Given this list of marker genes CYP4X1, FANCG, SNAI1, REV1, SIRT3, FZD7 (frizzled class receptor 7), TEX261, RBM4, EDIL3, SLC9A9, SSH3, CTSH, PAN3, ASAP1, TAOK1, APC, NAALADL1, VCF2, FMOD, LGALS1, G0S2 (G0/G1 switch 2), TMEM119, BTBD8, MANEA, ZC3H10, SUCLA2, FAM161A, SOX17 (SRY-box transcription factor 17), CP, SLC18A1, UCHL1, MS4A6A, CRH, BHLHE41, SGIP1, DLEU2, SUFU, ABL2, BMPR2, XAGE1A, SHCBP1, CRIM1-DT, IRF4, S100A12, PRKAA2, HEY1, LTBP1, C11orf96 (chromosome 11 open reading frame 96), WDR81, HMG20A, TNNI3K, ARHGAP36, SLC2A2, USP31, PSME4, SOAT1, MS4A4A, GABPA, PART1, CD86, MAP9, TTC38, PAX8, GPR108, ARID4A, RNF32-DT, NDUFA10, ACER3, EEF1AKMT2, CLDN12, ACVR2A, ALDH8A1, TCFL5, here is a description of the gene set: Genes up-regulated in normal keratinocytes immortalized by infection with the high risk HPV31 (human papilloma virus) strain. species: Homo sapiens Human Gene Set: CHANG_IMMORTALIZED_BY_HPV31_UP from publication Chang YE, Laimins LA (PMID 10756030) Human papillomaviruses (HPVs) infect keratinocytes and induce proliferative lesions. In infected cells, viral gene products alter the activities of cellular proteins, such as Rb and p53, resulting in altered cell cycle response. It is likely that HPV gene products also alter expression of cellular genes. In this study we used microarray analysis to examine the global changes in gene expression induced by high-risk HPV type 31 (HPV31). Among 7,075 known genes and ESTs (expressed sequence tags) tested, we found that 178 were upregulated and 150 were downregulated twofold or more in HPV31 cells compared to normal human keratinocytes. While no specific pattern could be deduced from the list of genes that were upregulated, downregulated genes could be classified to three groups: genes that are involved in the regulation of cell growth, genes that are specifically expressed in keratinocytes, and genes whose expression is increased in response to interferon stimulation. The basal level of expression of several interferon-responsive genes was found to be downregulated in HPV31 cells by both microarray analysis and Northern blot analysis in different HPV31 cell lines. When cells were treated with alpha or gamma interferon, expression of interferon-inducible genes was impaired. At high doses of interferon, the effects were less pronounced. Among the genes repressed by HPV31 was the signal transducer and activator of transcription (Stat-1), which plays a major role in mediating the interferon response. Suppression of Stat-1 expression may contribute to a suppressed response to interferon as well as immune evasion.